The following is a description of a gene set: Genes down-regulated in CD4 T cells from lymph nodes: naïve versus day 28 after immunization. studied in species Homo sapiens from publication Fazilleau N, Eisenbraun MD, Malherbe L, Ebright JN, Pogue-Caley RR, McHeyzer-Williams LJ, McHeyzer-Williams MG (PMID 17529982) Mice were immunized with PCC (pigeon cytochrome c). Human Gene Set: GSE7548_DAY7_VS_DAY28_PCC_IMMUNIZATION_CD4_TCELL_DN, and this is the list of marker genes: LSM4, AIM2, C2, DESI1, SMARCC1, SLC29A2, PRIM1, RPP40, LYSET, FLAD1, PARK7, HLA-F, ANKMY2, THOC2 (THO complex subunit 2), BAK1, MT3, IGFBP4, SNRPB, EIF3K, GP5, CNTNAP2, CLC, IL2RG, PAFAH1B3, PSMB2, CTSH, COX4I1, ASCL2, CHI3L1, SURF1, GART, RPA3, GUCY1A1, ITGB2, S100A8, LGALS3BP, EIF3I, TES, LIG1, BTN3A2, CLIC2, GSAP, PSMB10, NDUFB7, HLA-G, LAG3, CHD1L, PHLDA2, RABGGTA, VPS11, PSEN1, MT1E, PCCB, FLOT2, TSC2, BTN3A1, DFFB, SELL, POLDIP3, CALCOCO2, BLNK, BTN3A3 (butyrophilin subfamily 3 member A3), DDB2, PAX2, PSMB3, RRS1, PRCP, RIPOR2, EXOSC7, ZNF688, IDO1, PPP1R7, IDUA, SNTB2, WDR18, DBF4, SSR4, UBE2S, AKR1A1, HSD17B1, INPP5D, BST1, TXNIP, SNX3, INVS, LAMP3, ZNF593, TRIB2, UBA7, SVEP1, YJU2, CXCL11, GNAL, APEX1, HLA-DPA1, ADGRE5, MTHFD1, FAM53B, H2BC21, VAMP5, MTMR11, PEX7, SLC6A12, POLRMT, FCN1, PLAAT4, UBB, TAPBP, HAUS7, PLAT, STX3, ICAM2, GUCY1B1, NAB2, AQP4, PPP1R11, FGL2, MRTFA, ECI1, YBX1, PSME1, CFH, PUM3, PSMB9, FCGR1A, SIK1, BCAP29, RBMS2, CEBPG, LSM7, DGKG, TMEM131L, TCP11L1, MROH7, PSEN2, SLC7A7, PLP2, PCMT1, IRF4, APLNR, SPTA1, VRK1, CAPN2, VPS41, ARHGEF11, INSM1, ME1, TRMT1, GDPD5, TRHR, KCNQ1, COX5B, NR1I2, TNF, NHP2, MPDZ, SPRR2D, MT1F, RAP1GAP2 (NCBI Gene Id 388321), TAF10, HLA-DQB1, MT1A, CXCL9, NUP93, POLR1F, KCNE1, TRANK1, RFC2, ZFP36L2, USP6NL, LARP1, FKBP1B, NDUFA7, ETHE1, FKBP8, SEMA6A, PRKCD, TGM1, PSME2, C2CD2, NXF1, MFN1, GSTZ1, GCLC, PTPA, SLC49A3, SERPINA1, GRIK3, RAB40B, MEIS2, IER2, DEFB1, TXNRD2, SP1 (NCBI Gene Id 6667), WARS1, SND1-IT1, PSMA6, RPS6KA5, BARD1